Given this list of marker genes Sart1, Lsm2, Usp39, Sf3b2, Txnl4a, Smn1, Lsm1, Arfgef1, Eftud2, Gemin6-ps, Sf3b3, Snrpa1, Txnl4b, Snrnp27, Prpf6, Ppih, Ddx23, Larp7-ps, Snrpe, Luc7l3, Snrpc, Lsm11 (NCBI Gene Id 72290), Snrpa, Lsm4, Snrpd3, Snrnp70, Lsm3, Snrpb2 (U2 small nuclear ribonucleoprotein B), Hexim1, Prpf40a, Luc7l (NCBI Gene Id 72300), Gemin6, Gemin2, Snrpg, Fmr1, Sf3b1, Snrpf, Gemin4, Snu13 (NCBI Gene Id 20826), Slu7, Rbm42, Gemin8, Nolc1, Lsm5, Prpf31, Sart3, Snrpd2, Ddx20, Prpf4, Sf3a2, Snrpd1, Ddx39b, Prpf8, Strap, Lsm10, Cd2bp2, Clns1a, Lsm8, Htatsf1, Gemin7 (gem nuclear organelle associated protein 7), Sf3b5, Prpf39, Prpf3, Snrpert, Sf3a1 (splicing factor 3a, subunit 1), Lsm6, Sf3b4, Larp7, Sf3a3, Prpf18 (NCBI Gene Id 67229), Luc7l2, Zmat2, Snrnp200, Lsm7, Gemin5 (gem nuclear organelle associated protein 5), Phf5a, Rbmx2, Snrpb, Prpf40b, Snrpn, Mepce, Ppihl, Snrnp40, Tssc4, here is a description of the gene set: studied in species Mus musculus A protein complex containing members of the Like-Sm family of proteins, which includes both the Sm proteins and the Lsm proteins, and which generally form hexameric or heptameric ring structures which bind to RNA. While some of these ring complexes may form independently of RNA, many only form in association with their target RNA. In addition to Lsm-family proteins, many of these complexes contain additional protein members. Members of this family of complexes include the snRNPs which comprise the majority of the spliceosome. Others are involved in the 5' to 3' degradation pathways of mRNAs in the cytoplasm and of unspliced transcripts in the nucleus, as well as other diverse roles. Mouse Gene Set: GOCC_SM_LIKE_PROTEIN_FAMILY_COMPLEX